The following is a description of a gene set: from publication Chen Y, Wang X (PMID 31504780) Genes predicted to be targets of miRBase v22 microRNA mmu_miR_291a_5p in miRDB v6.0 with MirTarget v4 prediction scores > 80 (high confidence targets). Mouse Gene Set: MIR_291A_5P species: Mus musculus, and this is the list of marker genes: Mup14, Mup19, Prex2, Snrpd3, Scai, Ntpcr, Nsmce2, Bcl2l11, Cggbp1, Rp2, Prl3a1, Pak3, Lars1, Arl14ep, Efhc2, Ubqln2, Lnpep, Acsl4, Or51e2, Mup7, Epha7, Creld2, Chst5 (NCBI Gene Id 56773), Prpf40a, Tram1, Celf4, Hectd2, Mcf2l, Smad1, Ltbp1, Zfp523, Taf5, Cntn4 (NCBI Gene Id 269784), Rrh, Rab21, Nckap1, Arhgap29, Wnk3, Rnf139, Trps1 (transcriptional repressor GATA binding 1), Emilin3, Mnat1, Pabir2, Has2, Nhsl3, Zmynd11, E2f1, Hnrnph1, Rer1, Stard4, 2310022B05Rik, Mup2, Fndc3b, Lipo2, Fam120a, Fsd1l, Adam2, Slc44a5, Agtr2, Zim1, Nf1, Ammecr1, Prorsd1, Kdsr, Bmpr2, Cdkn2c, Cmpk1 (cytidine/uridine monophosphate kinase 1), Nt5dc1, G6pc1, Thg1l, Ap1ar (adaptor-related protein complex 1 associated regulatory protein), Ranbp3l, Calhm2, Mindy2, Acer3, Chic1, Mprip, Tmem161b, Tent2, Fyttd1 (NCBI Gene Id 98031), Ppp1r16b, Derl2, Kbtbd2, Nup93, Fgb, Spdye4a, Erbin, Zc3h12c, Nbeal1, Stambpl1, Arap3, Mup8 (NCBI Gene Id 100041687), Myzap, Cry1, Pcdh20, Cacna1b, Fam241a, Flrt2, Or51ab3, Cbx3, Cox17, Abca1, Ubqln1, Mup1, Fzd3, Gjc3, Ankib1, Fam163a, Mosmo, Gosr1, Misp3, Slain1, Spink5, Nop58, Sestd1, Med1, Anks1, Herpud2, Phactr3, Plagl1, Rragd, App, Hnrnpm, Rc3h2, Pdhb, Wdr26, Vopp1, Cpeb2, Cxadr, Cks1b, Sptssa (serine palmitoyltransferase, small subunit A), Fut8, Zfp709, Fam13c (family with sequence similarity 13, member C), Ttc13, Tmem106b, Cacul1, Prok2, Rpgrip1l, Tollip, Cul5, Dicer1, Klhl29, Mup10, Lipo3, Kdm7a, Defb6, Zfand6, Zbtb41, Mup9, Fam118a, Csnk1e, Tnfaip8, Rap1b, Mup12, Cyp1b1, Hcn1, Mup13, Parg, Xpnpep1, Cxxc4, Mtdh, Ptbp3, Bmpr1a, Snx7, Klhl2, Snx4, G3bp2, Trp73, Tead1, Dpyd, Zcchc2, Cntn3, Fam76b, Acss3, Zmiz1, Gria3, Tmem39b, Car10, Atg5, Clock, Phtf2 (putative homeodomain transcription factor 2), Nup58, Trim2, Mup18, Naa30 (NCBI Gene Id 75009), Slc12a2, Phf20l1, Gpr158, Lrig2, Abca5, Mup15, Ebf3, Nkrf, Scamp1, Fndc3a, Uqcrfs1 (NCBI Gene Id 66694), Rfx5